The following is a description of a gene set: In this study, an extensive analysis was conducted to define meta-programs (MPs) capturing intra-tumor heterogeneity across a spectrum of tumor types. The approach utilized non-negative matrix factorization (NMF) to analyze each cell type separately within individual tumor samples. This involved the analysis of malignant cells, macrophages, fibroblasts, endothelial cells, epithelial cells, T-cells, and B-cells. NMF was executed with varying parameter values (K=4, 5, 6, 7, 8, 9), thereby generating 39 programs for each cell type per sample. Each NMF program was summarized by the top genes based on NMF coefficients.\nRobust MPs were then delineated for each cell type using a set of stringent criteria, including recurrence within the same tumor, similarity to programs in other tumors, and non-redundancy within a tumor. Subsequently, these robust NMF programs were clustered (per cell type) based on Jaccard similarity, leading to the identification of MPs associated with each cell type.\nTo enhance the quality of the MPs, a refinement steps were undertaken, involving the removal of MPs suspected of reflecting low-quality data (with an overrepresentation of ribosomal proteins or mitochondrial-encoded genes), single-study inclusion, or similarity to miss-annotated cell types. species: Homo sapiens Human Gene Set: GAVISH_3CA_METAPROGRAM_FIBROBLASTS_CAF_5 Genes upregulated in subsets of cells of a given type within various tumors from publication Gavish A, Tyler M, Greenwald AC, Hoefflin R, Simkin D, Tschernichovsky R, Galili Darnell N, Somech E, Barbolin C, Antman T, Kovarsky D, Barrett T, Gonzalez Castro LN, Halder D, Chanoch-Myers R, Laffy J, Mints M, Wider A, Tal R, Spitzer A, Hara T, Raitses-Gurevich M, Stossel C, Golan T, Tirosh A, Suvà ML, Puram SV, Tirosh I (PMID 37258682), and this is the list of marker genes: CD9, ACTA2, PHLDA2, TM4SF1, NTRK2, GADD45B, MT1M, THBS1, IGFBP2, LMOD1, NNMT, DEPP1, CLU, TAGLN, LTBP1, ASPN, SYNPO2, HSPA1A, PLN, TIMP3, LBH, MT1E, S100A6, CRYAB, ACTG2, RERGL, MSRB3, PPP1R12B, SORBS2, TXNIP, NDUFA4, CCN1, BCAM, IGFBP5, PDLIM5, NEXN, EGR1, MTHFD2, MYH11 (myosin heavy chain 11), RARRES2, FXYD1, CNN1, S100A4, AEBP1, LITAF, PDK4, MT1X, CSRP1, COL14A1, NET1